Given this list of marker genes Bace1, Atp1a3, Abr, Stac2, Hexb, Pten, Mdga2 (MAM domain containing glycosylphosphatidylinositol anchor 2), Uchl1, Mfsd8, Fkrp, Ighmbp2, Bloc1s4, Vps54, Pou4f2, Tcap, Comp, Aph1c, Slc6a3, Pou4f1, Ednra, Itpr1, Pou4f3, Penk, Hoxc10, Jph3, Hexa, Mtor, Chrnd, Dvl1, Drd4, Get1, Zmpste24, Kcna1, Cntnap1, Washc4, Iglon5, Npas1, Ankfn1, Myh10, Ctnna2, Rogdi, Tnnc2, Nrxn1, Cav3, Spg21, Slitrk6, Nlgn2, Neurog1, Rcsd1, App, Mylk2, Tnnt3, Dmpk, Dctn1, Ap1s2, Clrn1, Tnni3, Grin2b, Hsp90aa1, Chd8, Tnni2, Tnnc1, Foxs1, Tcf15, Cntnap2 (contactin associated protein-like 2), Gch1, Shank3, Gpr88, Uba5, Selenon, Hottip, Homer1, Dmd, Myh3, Cdh23, Aldh1a3, Drd3, Vps35, Npas3, Slc1a3, Pomk, Grin2d, Npr2, Stra6 (NCBI Gene Id 20897), Chrne (NCBI Gene Id 11448), Actn3, Ddit3, Fgf14, Fgf12, Hipk2, Tifab, Gm2a, Grin2c (glutamate receptor, ionotropic, NMDA2C (epsilon 3)), Myo5a, Prrt2, Prkn, Drd2, Vps13a, Glra1 (NCBI Gene Id 320836), Sptbn4, Grin2a, Ei24, Prkd1, Pafah1b1, Grcc10, Otof, Cacna1a (calcium channel, voltage-dependent, P/Q type, alpha 1A subunit), Stac, Tnf, Nbn, Sox2, Fxn, Ascl1, Atp8a2, Gigyf2, Scn1a, Ush1g, Rubie, Atxn2, Glrb, Rps6kb1 (NCBI Gene Id 72508), Tnr, Adcy5, Shank1, Elp6, Synm, Spr, Kcnab2, Dbn1, Opa3, Mecp2, Kcnma1, Rnf170, Aph1b, Abl1, Slurp1, Nr4a1, Myo7a, Pde8b, Map1a, Rbfox1, Scn4a, Pex5, Camk2b, Jph4, Gbx1, Rbfox2, Grin3a, Rac3, Tnni1, Ucn, Kcnh1, Ptprq, Csmd1, Casq1, Nkx6-2, Myh7, Cln3, Chrna1, Kcnj8, Tuba1a, Xrcc1, Icmt, Borcs7, Adora2a, Pmp22, Myh8 (NCBI Gene Id 544790), Slc8a3, Dlg4, Fabp7, Kcnj2, Comt, Chrnb1, Vti1a, Gmppa, Abcc8 (ATP-binding cassette, sub-family C member 8), Cln8, Hoxd10 (NCBI Gene Id 99125), Gba1, Camta1, Zfp212, Nefl (NCBI Gene Id 18039), Strit1, Lonrf2, Myh14, Herc1, Adrb2, Nlgn3, Atp2b2, Spart, Cfh, Tshz3, Rest, Aplp2 (amyloid beta precursor-like protein 2), Aars1, Psap, Tpp1, Agtpbp1, Kbtbd13, Drd1, Adarb1, Hoxa1, Chrng, Bcr, Clic5, Atp2a1 (NCBI Gene Id 11937), Nr4a3, Abl2, Hmx3, Tnnt1, Grin1, Tmem150c, Pcdh15, Stac3, Cwh43 (cell wall biogenesis 43 C-terminal homolog), Rem1, Jsrp1, Igdcc3, Grid2, Ccdc78, Gaa, Ush1c, Pnkd, Large1, Mycbp2, Mdga1, here is a description of the gene set: species: Mus musculus Any process pertaining to the functions of the nervous and muscular systems of an organism. Mouse Gene Set: GOBP_NEUROMUSCULAR_PROCESS